The following is a description of a gene set: Human Gene Set: WIEDERSCHAIN_TARGETS_OF_BMI1_AND_PCGF2 from publication Wiederschain D, Chen L, Johnson B, Bettano K, Jackson D, Taraszka J, Wang YK, Jones MD, Morrissey M, Deeds J, Mosher R, Fordjour P, Lengauer C, Benson JD (PMID 17452456) Bmi-1 and Mel-18 are structural homologues that belong to the Polycomb group of transcriptional regulators and are believed to stably maintain repression of gene expression by altering the state of chromatin at specific promoters. While a number of clinical and experimental observations have implicated Bmi-1 in human tumorigenesis, the role of Mel-18 in cancer cell growth has not been investigated. We report here that short hairpin RNA-mediated knockdown of either Bmi-1 or Mel-18 in human medulloblastoma DAOY cells results in the inhibition of proliferation, loss of clonogenic survival, anchorage-independent growth, and suppression of tumor formation in nude mice. Furthermore, overexpression of both Bmi-1 and Mel-18 significantly increases the clonogenic survival of Rat1 fibroblasts. In contrast, stable downregulation of Bmi-1 or Mel-18 alone does not affect the growth of normal human WI38 fibroblasts. Proteomics-based characterization of Bmi-1 and Mel-18 protein complexes isolated from cancer cells revealed substantial similarities in their respective compositions. Finally, gene expression analysis identified a number of cancer-relevant pathways that may be controlled by Bmi-1 and Mel-18 and also showed that these Polycomb proteins regulate a set of common gene targets. Taken together, these results suggest that Bmi-1 and Mel-18 may have overlapping functions in cancer cell growth. species: Homo sapiens Genes up-regulated in DAOY cells (medulloblastoma) upon knockdown of both BMI1 and PCGF2 by RNAi., and this is the list of marker genes: PAPPA, FOSL1, KCNN3, SAFB2, DNMT3B, MICAL2, JUN, MMP7, PLAUR, CCND1, CRISPLD2, ADM, LRRC8A, NET1, NAV2, NAV1, MAP1B, S100A2, ITGA3, GAL, P4HA2, INHBA, LFNG, FAM43A, SDC3, EDN1, TPM1, TEK, BMP5, MYOF, F2RL1, MICB, ITGB8, GADD45A, KRT75, ABLIM3, IL7R, PLAT (plasminogen activator, tissue type), RFLNA, BCL7A, CAV1, PODXL, ITGA4, PTHLH, RREB1, CCDC80, MICA, CLDN1, CDK6, TIMP3, COL5A1, BMP1, RHOD, MICALL1, AXL, CPA4, ADAM19